Given this list of marker genes Rsad2, Traf6, Nlrp3, Tbx21, Xcl1, Malt1, Dennd1b, Il1r1, Map3k7, Traf2, Il18, Cd55, Fzd5, Cd55b, Il1b, Arid5a, Gata3, Slamf1 (signaling lymphocytic activation molecule family member 1), Il4, Prkcz, Il6, Sash3, Cd81, Tnfsf4, Il18r1, B2m, here is a description of the gene set: Mouse Gene Set: GOBP_POSITIVE_REGULATION_OF_T_CELL_CYTOKINE_PRODUCTION species: Mus musculus Any process that activates or increases the frequency, rate, or extent of T cell cytokine production.